Given this list of marker genes ACVR2B, SMARCA4, RBPJ, DLL4, DOCK6, OTUD5, CRELD1, MMP21, NKX2-6, DVL3 (dishevelled segment polarity protein 3), ARHGAP31, ESS2, FLT4, PKD1L1, NOTCH1, TRAF7, CHD7, DGCR6, PLD1, DGCR8, GDF1, ESAM, EOGT, FADD, TMEM94, TBX1, STRA6, BRD4, PLXND1, CIROP, DGCR2, NKX2-5, NODAL, FRA10AC1, here is a description of the gene set: species: Homo sapiens Pulmonary artery atresia Human Gene Set: HP_PULMONARY_ARTERY_ATRESIA A congenital anomaly with a narrowing or complete absence of the opening between the right ventricle and the pulmonary artery.